Given this list of marker genes Vstm2a, Lrrc55, Camta1, Cttnbp2, Ep300, Zfp644, Serpini2, Mapk10, Zfp710, 1700030J22Rik, Cdx4, Zfp322a, Ms4a6c, Rap2a, Sema3e, Klkb1, Cd160, Tmem241, Tbpl1, Khdrbs2 (KH domain containing, RNA binding, signal transduction associated 2), Pitpnm3, Mtcl3, Vps4b (vacuolar protein sorting 4B), Eif4b, Hs3st3b1, P2ry1, Cux1, Dock8, Derl1, Dip2c, Plagl2, Rab3gap1 (RAB3 GTPase activating protein subunit 1), Rab3b, Bmt2, Irf2bp2, Celsr2, Thrb, Tlr11, Cp, Rarb, Adgrl2, Gemin6, Hipk3, Pcgf3, Zfp992, Pias1, Adarb2 (adenosine deaminase, RNA-specific, B2), Tubgcp4, Ccdc88a, Col13a1, Mecom, Pdzd7, D630045J12Rik, Wsb1, Noc3l, Med18, Elk1, Enpp4, Dmwd, Galnt14, Kdm1b, Aplnr, Pik3ip1, Clip3, Lhx9, Ikzf2, Gabrr1, Fgfr2, Wdr26, Tmprss11b, Cdk4, Dennd6a (DENN domain containing 6A), Zfp598, Pgm3, Grhl2, Insc, Corin, here is a description of the gene set: from publication Chen Y, Wang X (PMID 31504780) Genes predicted to be targets of miRBase v22 microRNA mmu_miR_669e_5p in miRDB v6.0 with MirTarget v4 prediction scores > 80 (high confidence targets). studied in species Mus musculus Mouse Gene Set: MIR_669E_5P